Given this list of marker genes Erbb2 (NCBI Gene Id 13866), Ntrk2, Itga2, Tyro3, Epha10, Kdr, Egfr, Insrr, Oscar, Mertk, Fgfr1, Ephb1, Epha4, Tek, Insr, Epha6 (NCBI Gene Id 13840), Epha3, Met, Ephb3, Ddr1, Mst1r, Ephb2, Kit, Ntrk3, Tie1, Igf1r, Gp6 (NCBI Gene Id 636242), Flt3, Fgfr4, Erbb4, Alk, Pdgfra, Pdgfrb, Epha8, Fgfr3, Ephb4, Axl, Ros1 (NCBI Gene Id 19886), Ret, Epha1, Musk, Flt1, Epha2, Itga11, Ror2, Epha7, Fgfr2, Epha5, Ltk, Flt4, Csf1r, Ddr2, Ntrk1, here is a description of the gene set: species: Mus musculus Combining with a collagen and transmitting the signal from one side of the membrane to the other to initiate a change in cell activity. Mouse Gene Set: GOMF_COLLAGEN_RECEPTOR_ACTIVITY